Given this list of marker genes TMC5, FABP5, CEMIP, SPP1, IL6, PAM, ESYT2, ADH4, GJB2, NDUFAF7, RAB40B, REV1, TOMM20, ZNF292, MAVS, EP300, ZMPSTE24-DT, ENO2, ZNF512B, ZBTB7A, CLDN10, GLUL, HEY1, ARID5B, CGA, ZNF493, RASSF8-AS1, CAST, TBL1X, PDK1, SLC24A3, STC1, CTBP2, ZDHHC4, TRIB1, PDE4D, COPZ1, CHMP3, LONP2, PCDHB10, WSB1, RRAGA, FBXL3, GMDS, ERMP1, SOCS3, RBL2, NCK1, CYBRD1, BNIP3L, RHOBTB3, EPM2AIP1, OAS1, TUSC3, BTBD3, STAT6 (NCBI Gene Id 6778), RAB30, LETMD1, EHF, SNHG7, TIA1, PAG1, PIK3R3, FBXO9, SORL1, ACYP2, LCN2, NCOA7, KCNK3 (NCBI Gene Id 3777), SSR1, SYNE2, RHOV, HNMT, MZF1, SRSF6 (serine and arginine rich splicing factor 6), GYS1, CLK4, TMEM45A, H3C6, SEC24D, APCDD1, GOLGA8A, TEFM, SEC16A, SNN, RAB43, TPBG, H2BC5, NFIL3, AK3, UGP2, TMUB2, TTC31, ZNF207, ZNF703, UBE2Q2P1, NPTX1, CTSH, CCNG2, ZNF395, ERO1A, RORA, C11orf96, MED28, CYP24A1, DCAF10, FNDC3A, P4HA1, SH3BGRL, SYTL1, S100A8, NAB2, S100A9, H19, GAS1, MMP24OS, RPS4XP9, ABCC3, DRAM2, RYBP, HNRNPL, RPL15, IQSEC2, NMRK1, MFSD1, PRAG1, BTBD1, SAMD8, DNAJC5, LITAF, BAG1, KDM5B, NOTCH2NLA, DNAJC4, LSP1P5, SERPINB1, SLC5A3, DMD, KLF13 (KLF transcription factor 13), ATG2A, FNBP1, PDE8A, PSPH, RGCC, PCDHB14, MYSM1, ENSA (NCBI Gene Id 51620), ARFGAP3, ENOSF1, C11orf54 (chromosome 11 open reading frame 54), MIR210, PODNL1, FNTA, GART, CNOT8, ZFAND2A, ARG2, RERE, KRT15, SIAE, POM121, PHKB, PRKAR1A, TMC4, PDE10A, BNIP3, LAMP2, NEAT1, H2AC18, LRATD1, C4orf3, BACH1, IRX3, GCNT3, TTC28, COSMOC (cell fate and sterol metabolism associated divergent transcript of MOCOS), GABPB1-AS1, HIBADH, XDH, ZRANB2, FAM153A, GLYR1, D2HGDH, PIAS2, RB1CC1, CARD6, DOK1, ASS1, SERPINB3, LOX, HNRNPU, OBSL1, CAT, YPEL5, CBX4, KMT5B, SGPP2, TIMP1, PNRC1, MUC4, ANKRD37, ZNF91, PIGV, ZNF680, CFH, RARRES1, TIMMDC1, MXI1, NAMPT, GOLGA8G, SLC1A1, KDELR2, DHRS13, RPL31, RNF125, NR4A2, DUSP1, EREG, ARID1B (AT-rich interaction domain 1B, NCBI Gene Id 645070), IFIT5, STC2, GUSBP14, ABHD18, LINC02889, ANKRD13C-DT, KDELR3, SLC2A10, DPYD, AFAP1, ABI1, CCNT2, ACOX1, PLAGL1, PILRB, IL1RL1, VLDLR (very low density lipoprotein receptor), COMMD6, SLC6A14, WFDC2, CPD, ANKRD9, FGFR3, SH3YL1, PLIN2, SNHG8, LXN, IGSF3, HLA-F, IGBP1, LUM, SLC33A1, GOLGA8N (golgin A8 family member N), SLC16A14, SYT8, CCNG1, MACF1, ARHGAP45, IL1R1, ZNF587, ELF3, GABPB1-IT1, TXNIP, SOD2, ATP8B1, LINC02893, BIRC3, TNFRSF10D, ZBTB20, RAB40C, TSKU, TNFAIP2 (NCBI Gene Id 7127), ANK3, ATG14, SEMA6A, BCL11A, FOXN3, BCL2L11 (NCBI Gene Id 150819), HP, HNRNPA2B1, ANAPC16, PABPC4, CEP57, MKNK2, SATB1, YY1, WDR37, JUNB, CITED2, LINC01134, ITGA2, COL4A5, RSL1D1, SERTAD2, HERC2P1, FAM118A, NELL2, CPT1B, GAREM1, FGF7, H2AC6, N4BP2L2, PCDH7, NRP2, AQP3, ZNF44, HSD17B11, BCL6, MARCHF6, ZMYND8, RALGDS, MIDN, ARRDC3, SDC1, ZNF451, MARF1 (meiosis regulator and mRNA stability factor 1), RPL22, SELENOP, FZD10, FAT2, WDR11, SHC1 (SHC adaptor protein 1), NRARP, LINC00667, PGM2, ETS2, C1S, UBE2D3, LRRC37A2, LINC00470, RNF135, PON3, ZHX2, RAB9A, RNF187, ETFRF1, ZNF33A, ENSG00000307187, LINC00869, CHRAC1, PLOD2, RGL2, PNN, SNHG16, MALAT1, ITGB8, TLE5, TUG1, NUFIP2, SERPINB4 (NCBI Gene Id 6318), HSPA5, BAMBI, IGFBP5, TMEM165, SLC22A23, PHF3, IGFBP3, CYP4X1, LINC01667, VEGFA (vascular endothelial growth factor A), MRPL10 (mitochondrial ribosomal protein L10), AHNAK2, RAC2, PKM, ZNF131, KLHL28, TFPI, EVA1C, PGM1, CXCL16, UVSSA, PLXNB2, BTF3P13, FKBP1A, RAB11A, TEKT4P2, TMEM276, CXADR, CHST2, KRTCAP2, HK2, STEAP4, BCL3, RRAGD, ZNF24, HBP1 (NCBI Gene Id 26959), SRSF5, UNC5B, CALB1, TNFSF15, FAM222B, KIZ, H2AC25, TRIP11, TALAM1, TMEM245, SEZ6L2, PCSK1, C1RL, ZMIZ1 (zinc finger MIZ-type containing 1), SPTSSA, OTUD1, ADD3, RPL10P2, SHMT2, NABP1, PTGS2, HLA-E, RAB31, AUH, EBLN3P, FAM13A, RAB3D, RPL10, FUCA1, ADM, SLC7A2, ARNT2, ADSS1, DNAJB1, SGSM2, ABHD17C, GRAMD1C, ARHGEF7, ABHD6, TRIM29, C2orf68, BMERB1, CPE, CEBPB (CCAAT enhancer binding protein beta), SPG11, NDRG1, AZI2, RALGAPA2, XIAP, KRT13, IL20RB, GUSB, SH3BGRL3, IFITM1, LRIG1, CREB3L2, SLFN5, FNDC3B, TMEM47, ANKHD1, GALC, SEMA4B, SNCAIP, FAR2P2, MKRN1, PTP4A1, SAV1, KLF11, CHI3L1, FAM234A, ASPH, LEPROT, TTC3, TNS1, EGLN1, CCDC18-AS1, AGRN, ST6GALNAC2, PLAT, NISCH, KLF5, SLPI, PI3, MT-ND5, MUC1, C3, RPL28, DENND10P1, ADARB1, CAMKK2, EIF3LP3, RAB24, ACKR3, BACE2, ZG16B (zymogen granule protein 16B), FTH1, B4GALT5, GLRX, CP, SYT17, KDM4B (NCBI Gene Id 23030), IGFBP1, RPL37, FOSL2, SRGN, CACHD1, PDCD4 (programmed cell death 4), CXCL5, TESC, CHST15, MCEE, ERCC6L2, PPARA, STX4, RPL13, NCKAP1 (NCBI Gene Id 9864), CDH1, ASXL1, ENSG00000307470, FOXC1, SFPQ, PCMTD1 (NCBI Gene Id 115294), WDR72, SYT12, KSR1, GTF2I, TNFSF10, TRIM56, CEBPD, LRG1, CHMP4B, LPAR3, PAPSS2, NXPH4, SLCO4A1, BPTF, CREG1, HLA-B, ANP32A, ZBTB33, TOX4, MOB3A, PGK1, GNA15, FTX (FTX transcript, XIST regulator), GRHL1, EIF4A1, NATD1, ITM2B, PHAX, S100P, PTEN, JAG2, HLA-G, IL33, USO1, TSPAN1, IKBIP, LYZL4, OSBPL2, NUDCD2, PCSK6, CROT, ZNF580, SEC31A (SEC31 homolog A, COPII coat complex component), IKBKB, MUC5B, SLC46A3, RBM38, ARL17A, ZNF496, TC2N, RNF114, CACNA2D1, UGCG, EEF1AKMT3, INSR, NPHP3, PDE3A, SLF1, SMIM14, SLC35E1, COL27A1, ADAM17, NBR1, RAB4A, PLAG1 (PLAG1 zinc finger), KCNJ12, RBPJ, PDE4B, TMEM178B (NCBI Gene Id 100507421), KDM3A, FYCO1, ENSG00000278932, ACAD11, FAM83A, DELE1, FAM110C, SLC6A8, DENND4C (NCBI Gene Id 55667), ZNF226, AHSA2P, CCNY, EEF1A1, FOS, NKIRAS2, COL6A1, MAOA, BZW1, TMPRSS4, CLK1, EGLN3, TAPBP, HSPD1, SLC6A6, WASF2, CFI, LTA4H, STX5, ABCB7, TRPT1, MAN1B1-DT, NFATC2IP, AHR, SPINK13, HAS3, FA2H, RAB27B, GATAD1, SLC25A36, SPOCK1, SLC2A3 (solute carrier family 2 member 3), NAXD, ORAI3, CSNK1D, MESD, HERPUD1, LMO2, SPTBN1, MEGF6, LPAR6, KRT23, SLCO1B3, LOXL2, MAP3K13, RERG, WIPF2, P4HB, TCFL5, PCBP1-AS1, PARP6, RXRA, EBF4, CPS1, DUXAP8, HSPA6, CALM2, CCNL2, NRN1, CA9, CLEC2B, GPCPD1, CCL20, ROBO1, PNPLA8, RCOR3, here is a description of the gene set: species: Homo sapiens from publication Nakamura T, Kuwai T, Kitadai Y, Sasaki T, Fan D, Coombes KR, Kim SJ, Fidler IJ (PMID 17699763) Using Affymetrix HG-U133 Plus 2.0 array and laser capture microdissection techniques, we determined whether different zones of the same pancreatic tumor exhibited differential expression of genes. Human L3.6pl pancreatic cancer cells were implanted into the pancreas of nude mice. Three weeks later when tumors were 7 to 9 mm in diameter, gene expression patterns in tumor cells within the central and peripheral zones were compared, and genes showed statistically significant differences. Bioinformatic functional analysis revealed that 346 up-regulated genes in the peripheral zone were related to cytoskeleton organization and biogenesis, cell cycle, cell adhesion, cell motility, DNA replication, localization, integrin-mediated signaling pathway, development, morphogenesis, and IkappaB kinase/nuclear factor-kappaB cascade; 876 up-regulated genes in the central zone were related to regulation of cell proliferation, regulation of transcription, transmembrane receptor protein tyrosine kinase signaling pathways, response to stress, small GTPase-mediated signal transduction, hexose metabolism, cell death, response to external stimulus, carbohydrate metabolism, and response to wounding. The reliability of the microarray results were confirmed by in situ hybridization analysis of the expression of two genes. Collectively, the data showed zonal heterogeneity for gene expression profiles in tumors and suggest that characterization of zonal gene expression profiles is essential if microarray analyses of genetic profiles are to produce reproducible data, predict disease prognosis, and allow design of specific therapeutics. Down-regulated genes in peripheral zone of human pancreatic cancer growing in the pancreas of nude mice compared to that of the tumor from the central zone. Human Gene Set: NAKAMURA_TUMOR_ZONE_PERIPHERAL_VS_CENTRAL_DN